Given this list of marker genes HES1, ASCL1, EXT1, NPHP3, NKX6-3, KCNQ1, here is a description of the gene set: Human Gene Set: GOBP_STOMACH_DEVELOPMENT species: Homo sapiens The process whose specific outcome is the progression of the stomach over time, from its formation to the mature structure. The stomach is an expanded region of the vertebrate alimentary tract that serves as a food storage compartment and digestive organ.